Given this list of marker genes Fos, Jun (NCBI Gene Id 16476), Cd69, Klf6, Junb, Ctla2a, here is a description of the gene set: Cytokines mediate cell-cell communication in the immune system and represent important therapeutic targets. A myriad of studies have highlighted their central role in immune function, yet we lack a global view of the cellular responses of each immune cell type to each cytokine. To address this gap, the authors created the Immune Dictionary, a compendium of single-cell transcriptomic profiles of more than 17 immune cell types in response to each of 86 cytokines (>1,400 cytokine-cell type combinations) in mouse lymph nodes in vivo. A cytokine-centric view of the dictionary revealed that most cytokines induce highly cell-type-specific responses. For example, the inflammatory cytokine interleukin-1β induces distinct gene programmes in almost every cell type. A cell-type-centric view of the dictionary identified more than 66 cytokine-driven cellular polarization states across immune cell types, including previously uncharacterized states such as an interleukin-18-induced polyfunctional natural killer cell state. from publication Cui A, Huang T, Li S, Ma A, Pérez JL, Sander C, Keskin DB, Wu CJ, Fraenkel E, Hacohen N (PMID 38057668) Mouse Gene Set: CUI_T_CELL_CD8_FGF_BASIC_RESPONSE_DN Genes negatively differentially expressed in cell type: CD8+ T cell upon treatment with cytokine: FGF-β in mouse lymph nodes in vivo. species: Mus musculus